Given this list of marker genes MUTYH, KEAP1 (kelch like ECH associated protein 1), PMS2, SUFU, HRAS, FASLG, TMC6, FOXE1, KRAS, RMRP, NTHL1, DICER1, MLH1, ERCC2, COL7A1, TYMS, POLE, BRCA2, COL14A1, MMP1, COL17A1, AAGAB, MSH2, RECQL4, FAS, RPS19, POLD1, PMS1, SEMA4A, PTCH1, TGFBR2, BMPR1A, PTCH2, APC, XPC, EPCAM, OCA2, POLH, LMNA, MC1R, RASA1, WNT10A, ERCC5, CIB1, CASP10, RPS20, ATM, CHEK2, DDB2, NRAS, ANAPC1, MSH6, TYR, SMO, ERCC4, CYLD, PIK3CA, ERCC3, here is a description of the gene set: Basal cell carcinoma The presence of a basal cell carcinoma of the skin. Human Gene Set: HP_BASAL_CELL_CARCINOMA species: Homo sapiens